The following is a description of a gene set: Catalysis of the cleavage of a C-C bond by other means than by hydrolysis or oxidation, of a 3-hydroxy acid. Human Gene Set: GOMF_OXO_ACID_LYASE_ACTIVITY studied in species Homo sapiens, and this is the list of marker genes: NPL, CLYBL, HOGA1, TYW1B, HMGCLL1, TYW1, HMGCL